The following is a description of a gene set: Mouse Gene Set: GOMF_LONG_CHAIN_FATTY_ACYL_COA_HYDROLASE_ACTIVITY Catalysis of the reaction: a long-chain fatty acyl-CoA + H2O = a long-chain fatty acid + CoA + H+. A long-chain fatty acid has an aliphatic tail containing 13 to 22 carbons. species: Mus musculus, and this is the list of marker genes: Hnf4a, Ppt1 (NCBI Gene Id 97141), Baat, Them4, Pla2g6, Desi1, Cln5, Acot2, Acot9, Desi2, Acot7, Acot11 (NCBI Gene Id 68650), Acot8, Them5, Mblac2